The following is a description of a gene set: part of: Intrinsic Pathway for Apoptosis electronically inferred by orthology from the curated human pathway species: Mus musculus This event has been computationally inferred from an event that has been demonstrated in another species.<p>The inference is based on the homology mapping from PANTHER. Briefly, reactions for which all involved PhysicalEntities (in input, output and catalyst) have a mapped orthologue/paralogue (for complexes at least 75% of components must have a mapping) are inferred to the other species. Reactome Pathway: Activation, translocation and oligomerization of BAX, and this is the list of marker genes: Bax